The following is a description of a gene set: studied in species Homo sapiens part of: Wax and plasmalogen biosynthesis Reactome Pathway: Wax biosynthesis Waxes are esters of long chain fatty acids and long chain fatty alcohols that play an important role in protecting the skin surface from drying and abrasion. Enzymes that catalyze two reactions of wax biosynthesis have been characterized in humans. FAR1 and FAR2 catalyze the reduction of fatty acids to fatty alcohols in the peroxisome and AWAT1 and AWAT2 catalyze the reaction of fatty alcohols and acyl-CoA in the cytosol to form wax esters. The existence of a transport process, otherwise uncharacterized, to move fatty alcohols from the peroxisome to the cytosol is inferred from the observation that cultured cells that do not normally synthesize waxes can be induced to do so by co-transfection with DNA constructs encoding FAR and AWAT enzymes (Cheng & Russell 2004a,b)., and this is the list of marker genes: FAR1, FAR2, AWAT2, AWAT1